Given this list of marker genes ERBB2, CDC37, ERBIN, HSP90AA1, here is a description of the gene set: Reactome Pathway: Resistance of ERBB2 KD mutants to sapitinib studied in species Homo sapiens part of: Drug resistance in ERBB2 KD mutants This pathway describes resistance of ERBB2 KD mutants to tyrosine kinase inhibitor sapitinib.